The following is a description of a gene set: Cholesterol and palmitoyl-modification of Hh-Np render the ligand highly hydrophobic and results in its close association with the plasma membrane of the producing cell after secretion. Hh-Np tethered in this way may cluster in sterol-rich lipid rafts where it is competent for short-range signaling. Cell surface Hh-Np also interacts with glypican components of the extracellular matrix and this interaction stabilizes the ligand and is required for its lateral spread. Together, clustering into lipid rafts and interaction with HSPGs may favour packaging of ligand into higher order forms required for ligand dispersal.<br> Long-range signaling requires release of Hh-Np from the secreting cell. Release is achieved through a number of possibly overlapping mechanisms. These include oligomerization into micelle-like structures, packaging into lipoprotein particles and interaction with cholesterol-binding adaptor proteins such as DISP and SCUBE2. In addition, Hh-Np can be released from the plasma membrane through proteolytic cleavage: NOTUM is a secreted enzyme that is thought to promote the release of Hh-Np by cleaving the GPI anchor of Hh-associated glypicans, while the transmembrane metalloprotease ADAM17 promotes long-range Hh signaling by removing the palmitoyl- and cholesterol-modified N- and C-termini of the membrane-associated ligand. How all these mechanisms are coordinated remains to be elucidated. Reactome Pathway: Release of Hh-Np from the secreting cell part of: Hedgehog ligand biogenesis species: Homo sapiens, and this is the list of marker genes: IHH, DISP2, SHH, DHH, NOTUM (NCBI Gene Id 147111), SCUBE2, ADAM17, GPC5